The following is a description of a gene set: Neighborhood of TNFRSF1B tumor necrosis factor receptor superfamily, member 1B in the GNF2 expression compendium species: Homo sapiens Human Gene Set: GNF2_TNFRSF1B Neighborhood of TNFRSF1B, and this is the list of marker genes: MS4A6A, PSTPIP1, TNFRSF1B, FGR, NOD2, FCER1G, CASP1, RNF130, ARPC1B, DOK2, SLC7A7, FGL2, CCR1, ADGRE1, TCIRG1, LILRA2, CMTM6, DPEP2, S100A4, PYCARD, HSD17B11, LILRB3, RHOG, FCN1, NAGK, ITGB2, SH3BGRL3, HCK, PPT1, LILRA1, IGSF6, RIN3, LILRB2, LST1, PSAP, AOAH, TLR2 (NCBI Gene Id 7097), TMEM127, RGS2, LILRB1, TYMP, CPVL, CTSS, LILRA6, CLEC4A, CD1D, AIF1, LILRA3, AP1S2, TBXAS1, PECAM1, CYBB, GMIP, ARRB2, TYROBP, DUSP1, COTL1, MYD88, CNPY3, PILRA, ADA2, STXBP2, CFP, NCF2, THEMIS2